The following is a description of a gene set: Pathway Definition from KEGG: S -| ACE2 -| AngII -> AGTR1 -> NOX2 -> ROS -> NFKB -> (TNF,IL6,IL1B,IL12,MMP3,MMP1,CCL2,CXCL8) SARS-CoV-2 S to AngII-AT1R-NOX2 signaling pathway. Pathway ID: N01307. Pathway type: Pathogen. Pathway class: nt06171 SARS coronavirus 2 (SARS-CoV-2). Human Gene Set: KEGG_MEDICUS_PATHOGEN_SARS_COV_2_S_TO_ANGII_AT1R_NOX2_SIGNALING_PATHWAY species: Homo sapiens, and this is the list of marker genes: IL12B, TNF, MMP1, CCL2, IL12A, CYBB, IL1B, NFKB1, RELA, MMP3, AGTR1, ACE2, CXCL8 (C-X-C motif chemokine ligand 8), IL6